Given this list of marker genes Ptk2b, Jak2, Il4, Pibf1, Prlr, Il3, here is a description of the gene set: species: Mus musculus The process of introducing a phosphate group to a tyrosine residue of a JAK (Janus Activated Kinase) protein, thereby activating it. Mouse Gene Set: GOBP_ACTIVATION_OF_JANUS_KINASE_ACTIVITY